Given this list of marker genes ZNF827, SUZ12, NLK, SPOCK1, PTEN, GRIN2A, ANKRD29, ARHGAP11A, ARFGEF1, ADIPOR2, TFCP2L1, CFL2, ZFYVE9, PCDHA1, MYCN, SPTSSB, CNGA3, RNF11 (NCBI Gene Id 26994), CAPRIN2, CYP2U1, SLC49A4, MOSMO, CCNT2, CNOT7, WDFY3, TNKS, FAM168A, SIN3B, NUP54, ASAP2, USP8, TNPO2, RAI2, PIK3CA, B3GALNT2, WNK1, MYCL, MTMR6, ZNF518A, ITGA6, CDS1, RBMS3 (RNA binding motif single stranded interacting protein 3), MBNL2, ARSD, DDX3Y, TAOK1, BRWD3, SEC11A, CLOCK, BPTF, PCDHA3, SLC25A6, RPS6KA5, HNRNPUL2, EYA1, STK32B, ZNF609, BTF3L4, FLNC (filamin C), SOX5, SCN3A, MSMO1, ZER1, ROBO2, ZNF644, PCDHA10, RHEBL1, FOXP1, TXLNA, DOCK10, SOCS1, PGR, FAT3, RTN1, SOCS5, ADCY1, ERBB4, SOX4, PARPBP, RAB14, EPHX4, GULP1, SH3KBP1, PCDHA4, FUT9, SLC35F1, CAB39 (calcium binding protein 39), ZBTB10, RGL1, ROR1, F3, PPFIA2, UBL3, WDR44, SLC31A2, IL26, SIPA1L1, B4GALT5, SESN3, GRSF1, GTF2H1, NCKAP5, PCDHA13, SF3B3, FBXO48, S1PR1, TNFRSF11A, FMR1, EIF4G2, SOS2, ADCY7, TBK1, RNF145, ETV5 (NCBI Gene Id 2119), GRK6, MBNL3, FBXO32, ABR, PHTF2, NRK, FNDC3A, ATP6V0E1, EPN2, HERC4, ST8SIA3, DNAJA2, SLC6A6, FAM83D, ARFIP1, DOCK4, TET3, AUH, CNOT6L, PATL1, SPATA2, ZFP91, NCOA4, TSHZ3, DCUN1D3, GAREM1, RAP2C, NFIA, BAG5, DNAJC16, MAPK8, PHLDA3, CEP55, AMMECR1L, DENND6A, ATG14, MATN3, RICTOR, ATL2, PCDHA5, BAMBI, KBTBD8, CCNA2, JADE1, PPARA, PLAA, TENT5A, ELOVL5, PGM2L1, CAMSAP1, NDFIP2, LIN9, EMX2, ZDHHC7, SLC2A13, KLF7, ENC1, IVNS1ABP (influenza virus NS1A binding protein), UBE2D3, DBN1, SMURF1, PPTC7, STK35, LY75, SYT1, WBP4, RAP1A, KIAA2013, FAM43A, TBR1, EXOC5, NPTN (NCBI Gene Id 27020), SLC26A7, CHIC1, ZNF521, PCDHA9, SIVA1, ITSN1, MIGA2, ARC, MICAL2, IGF1, MED26, HPRT1, GSKIP, DCBLD2, YTHDF2, GABARAPL1, GJA1, EFNB2 (NCBI Gene Id 1948), SDC1, YIPF6, PLS1, BEND4, RAB21, GTF2A1, ZBTB20, CBX6, EREG, PI15, MBD2, SOCS3, GTDC1, EHBP1, PSAP, SLC4A7, MDM1 (NCBI Gene Id 56890), HCFC2, SV2A, ADSS2, USP33 (NCBI Gene Id 23032), SLC12A7, SAMD4A, PDIK1L, PCDHA11, CCND2, MECP2, MB21D2, KIF3A, RHOB, PRR5L, SYT11, WDR20, CASTOR2, MAP4K3, TNFRSF12A, POSTN, RCOR1, RBMS1, ATG16L1 (autophagy related 16 like 1), SLC6A11, MED13, OTUD1, HIPK1, ZNF367, ABCB7, CBLB (NCBI Gene Id 868), ANKRD42, HOMER1, PHF12, MDFIC, CCDC88A, CCM2, ZNF445, KIAA1217, TNRC6B, ZBTB18, NR3C2, NFIC, MAP3K2 (mitogen-activated protein kinase kinase kinase 2), DPYSL5, CAMSAP2, ATXN1, SMOC1, GOLGA6B (NCBI Gene Id 55889), CACNA1C, CLIP1, ACOX3, BTG1, MIER1, MRTFB, FOXP2, NAALADL2, RUNX2, SKIDA1, ATXN1L, UBE2A, BMPR2, JAZF1, ZFYVE26, UBE2D2, DIPK1A, SEMA4C, MTCL1, PIK3R3, N6AMT1, CDC42BPA, SGK1, UHMK1, GIT2, CCPG1, DMXL2, RNF111, SNX17, TMBIM6, RAPGEF4, PIK3CB, PHF13, CLIP4, TUB, FRMD4A, IGFBP3, WBP1L (WW domain binding protein 1 like), MOB1B, SMCR8, APPL1, EPS15, PCDHA7, DNAAF9, CCDC6, ZNF320, KIF13A, NPEPL1 (NCBI Gene Id 79716), CHST1, KCNA4, RIMKLA, IMPDH1, FASTK, PTPRG, ELMOD2, PCDHA12, MTCL2, MAP3K12, SHCBP1, CCNL1, FHIP1A, BRWD1, PSG1, ADRB1, PRC1, VTI1A, CRACD, KLF10, LSM12, VSTM2B, SMARCA2, RASSF2, PLXNC1, POU3F2, LRIG3, S100PBP, ADCY9, ABHD17C, DNAI1, GET3, PCDHA2, BTAF1, P3R3URF-PIK3R3, BNIP2, RBCK1, SHANK1, EMC7 (NCBI Gene Id 56851), EEIG1, MAGI2, MEF2A, PRUNE2, ZMYND11, SEL1L, BLCAP, LONRF3, PCDH7 (NCBI Gene Id 90855), LRIG1, ARHGAP12, REEP3, PCDH15, NPAS2, ARMC8, EOGT, BNC2, PAK6, TNRC6C, HECW2, LGALSL, ATP2C1, HNRNPUL1, COX8C, SERINC3, CSMD1, ACADSB, FAM114A1, PCDHAC1, KLHL42, LRRTM2, ESR1, SIX4, PITX1, MAPK1, SMAD5, ABCA1, SERPINE1, LLGL2, SLC9A6, ACSL4, HIP1, ABCC3, NAPB, SCUBE3, ATP10A, LDLR, SEPTIN7, MKRN1, ZDHHC18 (zinc finger DHHC-type palmitoyltransferase 18), ARRDC3, THSD7A, DLX3, PPP1R12A, PCDH10, RNF216, ACBD5, DESI2, ANO1, KLF13, ELL2, C2CD5, ZNF469, ARIH2, PARP8, MEX3C, SKIL, KRTAP3-1, AFTPH, DICER1, NAP1L2, CLTC, DDX3X (DEAD-box helicase 3 X-linked), KPNA6, ID2, SLC6A8, NFIB, INO80D, PNRC1 (proline rich nuclear receptor coactivator 1), TIA1, VPS37A, DSEL, ZMAT3, SAMD8 (sterile alpha motif domain containing 8), PFN2, ARAP2, NEUROD1, SMG1, PRICKLE2, ERBB3, CNOT6, PMEPA1, GRM1, C2orf42, CPD, MMGT1, TCIM (transcriptional and immune response regulator), GPR137B, PLXNA4, MGAT5, TENT2, KCNC4, MAPK14, ZNF680, JRKL, NAV3, ADNP, ATXN7, WDR1, FAM76B, MECOM, DUSP7, QKI, HBP1, RACGAP1, ZNF516, KCNQ5, OTUD7B, GSC, TRIM23, TGM3, RAPGEF2, ZNF385B, SLC16A7, ATP12A, NALF1, USP13, PON2, PDE3B, SH3D19, MAB21L2, TGIF1, SEC61A2, KCNJ2, ZBTB4, ATXN7L1, RBBP8, WDR26, OSBPL11, ANKIB1, GIGYF1, MED12L, EDARADD, LRP2BP, ATF2, ARHGAP21, RAB8B, MDM4, CACUL1, ARPP19, CBLN2, CAND1, TENT5B, ABHD5, E2F8, SNTG1, STOX2, TNFAIP3, PITPNM2, EXOC6B, KHDC4, RNF44, ZNF716, CNKSR2, BEND3, MSI2, G3BP2, BTBD7, FBXO8, PRKAA1 (protein kinase AMP-activated catalytic subunit alpha 1), MACF1, AKAP1, PLCB1, CCSER2, SOX6 (SRY-box transcription factor 6), ACTN1, AGPAT5, ZNRF3, SYNM, PPP2R5E, ARRDC4, ZNF217 (NCBI Gene Id 7764), MPPED2, ITGA2, CNTFR, SERPINB12, ZNF831, PYGO2, PRKACB, CCDC126, IL15, AQP5, GPCPD1, SP100, MFSD6, SRGAP2C, TAF4, MBD6, DDX6, PCDHA6, RAB18, ZBTB46 (zinc finger and BTB domain containing 46), FAM234A, MEMO1, LIMCH1, MLLT6, RAF1, DOCK3, ZBTB11, MAP3K1, SLC37A1 (NCBI Gene Id 54020), NBEAL2, GOLGA6A, RFX4, CREBRF, PRRT3, ST3GAL5, SRGAP2B, WNT3, IFI44L, EBF2, MAPK6, CASP10, RALGPS1, PCDHAC2, POU4F1, USP12, SYN1, RAP1B, REST, TMEM45A, CGN, KLHL11, TMEM64, ENPP5, TSC1, TRIM33, LRP2, ITCH, HIPK3, SLC24A3, KLHL20, MTRR, CCND1, ATP6V1B2, VPS4B, RORA, PCDHA8, ASXL2, CD164, NRBP1, RNF167, WDR45B, CHD2, WAC, ZDHHC23, CAST, LONRF1, GRAMD1B, ZBTB14, RAB1A, TMEM47, FZD6, STK26, RIN2, PDE5A, PKNOX1, SATB1, RABGAP1, VPS35, SRSF6, TTC9, DNAJB1, HDLBP, PHF14, DLG5, CYLD, BMP3, SBF2, VAMP3, KPNA3, MPHOSPH9, ITGB8, CEP350, MID1, AFF1, DLC1, DTNA, SULF1, C11orf96, HIC1, PTPRD, SECISBP2L, here is a description of the gene set: from publication Chen Y, Wang X (PMID 31504780) Human Gene Set: MIR19A_3P Genes predicted to be targets of miRBase v22 microRNA hsa-miR-19a-3p in miRDB v6.0 with MirTarget v4 prediction scores > 80 (high confidence targets). studied in species Homo sapiens